The following is a description of a gene set: species: Homo sapiens The process in which a relatively unspecialized cell acquires specialized features of a neuron whose cell body resides in the central nervous system. Human Gene Set: GOBP_CENTRAL_NERVOUS_SYSTEM_NEURON_DIFFERENTIATION, and this is the list of marker genes: EN1, ERBB4, B4GALT5, TCTN1, ID4, UBB, OLIG2, GSX2, HPRT1, NDNF, BARHL2, BRSK2, DLX1, SKOR2, SLC25A46, PRKCA, RORB, MDGA2, TAOK1, GLI2, SFRP2, GABRB1, HOXD10, ZDHHC16, MAP2, SHH, SPTBN4, UNCX, AGTPBP1, NKX2-2, B2M, FGFR2, PAFAH1B1, WNT9B, FOXN4 (NCBI Gene Id 121643), UNC5D, ROBO1, DRD2, NFIB, LMX1A, LHX5, WNT5A, LDB1, ADARB1, ASCL1, ATP7A, LHX6, NOTCH1, CEND1, ISL2, NRP1, DCC, PEX5, BRINP3, MDGA1, LONRF2, PLXNA1, PAX6, FAIM2, ISL1 (ISL LIM homeobox 1), BRINP1, OPHN1, NTRK2, TOX, CHRNB2, PLXNA4, WNT3, CRKL, TBX20, FOXG1, PHOX2A (paired like homeobox 2A), IFT172, GSX1, UQCRQ, LRP6, WNT7A, RORA, BCL6, POU4F2, GDF7, ATOH1, ROBO2 (roundabout guidance receptor 2), HOXC10, NKX6-1, EPHA2, LHX8, SCYL2, EMX1, TGIF1 (TGFB induced factor homeobox 1), RAPGEF2, TULP3, RAC1, ARHGAP35, EPHA4, CLN8, SUFU, HERC1, SCYL3, DKK1, HES1, FEZF1, ITGB1, NHLH2, C12orf57, GDF11, OTP (orthopedia homeobox), BRINP2, EFNA1, OLIG3, ATF5, TFAP2C (NCBI Gene Id 7022), SPOCK1, KNDC1, GRID2, BMPR1B, NEUROD4, CDH11 (cadherin 11), TUBA1A, BMPR1A, DYNC2H1, FZD1, PSEN1, TBR1, NFE2L1, MAPT, NIN, NR2E1, SMO, DBX1, DAB1, FOXP2, SALL1, PTF1A, ARHGEF28, TSKU, TTC21B, MNX1, WNT2, SOX1, PALS1, SLIT2, C21orf91, OGDH, SCN1B, FBXO45, PHOX2B (NCBI Gene Id 8929), TTC36, NR4A2, LHX4, PROX1, SZT2, PTEN, NDEL1, EN2, DRD1, MAP2K1, POU3F2, ZHX2, PAX7, GBA2, CSNK1D, AGBL4, B4GALT6, CHD5, SLIT1, PTCH1, WNT3A, GBA1 (NCBI Gene Id 82008), WNT1, CNTN2 (contactin 2), KIFBP, BCL11B, RYK, ELAVL4, LHX1, CBLN1, SIN3A, NANOS1, SHANK3, LBX1, CTNNB1, NKX2-1, DLX2, MIB1, NPY, LHX3, HES5, SFRP1, TAL1, EOMES, GLI3, LEP, ZC4H2, ZSWIM6, INHBA, GIGYF2, ZNF335, DCLK2, NRXN1, NOVA2, MYCBP2, PLXNA3, SEMA3E, SCYL1, WDR47, GATA2, EPHB1, PRDM8, DRAXIN, KIAA0319, CRK, SPG11, BRSK1, EPHB2, FEZF2, DISC1, NRP2, CDK5, BTG2, SLIT3, DLX5, ABT1, VSX2, GBX2, TTLL1, SLC4A10, ZEB2, CDON, CSF1R, POU4F1, EPHB3 (NCBI Gene Id 2049), TGIF2, ARX, SECISBP2, FGF8, GBX1, NEUROD1, ZMIZ1, DMRT3, RAC3, LMO4, DLL4